The following is a description of a gene set: The process that results in the assembly of clathrin triskelia into the ordered structure known as a clathrin cage. Human Gene Set: GOBP_CLATHRIN_COAT_ASSEMBLY species: Homo sapiens, and this is the list of marker genes: DNM1 (NCBI Gene Id 1759), PIK3C2A, HIP1, NSG2, CALY, DAB2, HIP1R, CLINT1, AP2S1, CLTC, FCHO1, FCHO2, NSG1, EPS15, DNAJC6, GAS7, CLTA, PICALM, SNAP91, AP2B1, GAK